Given this list of marker genes Ywhab, Mtm1, Phlpp1, Ppp1cb, Ptpn5, Tmem225, Dusp16, Ptpro, Ppp1r35, Rpap2, Cd33, Dusp21, Ptprn, Slc39a10, Ppa2, Ptpn3, Ppp1r15a, Hsp90ab1, Ppp2r2a, Ppp2r5c, Dusp12, Cdc25a, Ppp1r3c, Bod1, Phactr1, Calm3, Ppm1b, Ppm1n, Ppp1r36, Ptprb, Ppp1r14a, Tns2, Ptprk, Ptprg, Styxl2, Ppp3r2, Dusp5, Ppp5c, Ppp3ca, Rngtt, Pald1, Rcan3, Ptpn23, Ptpn14, Cdc14b, Ppp1r11, Ptpn2, Ppm1a, Tns3, Ptprn2, Pdp2, Ptprs (NCBI Gene Id 19280), Fig4, Pgp, Ptprf, Cabin1, Ppp1r15b, Ppm1e, Ptpn20, Ptprt, Ptpn22, Ctdnep1, Ppp1r8, Dusp9, Ppp1r7, Ctdspl, Phlpp2, Ppp6r1, Dusp10, Ppp2r5d, Dusp7, Ppp4r3c1, Smtnl1, Ptprq, Ppp2r5e, Ppp2cb, Ppp1r10, Eya2, Ppp2r1b, Dusp11, Ppp1r2, Cnep1r1, Dusp19, Elfn2, Pabir2, Ppp1r1b, Eya4, Ppp1r1a (protein phosphatase 1, regulatory inhibitor subunit 1A), Ptpra, Ppp1r17, Dusp15 (NCBI Gene Id 99102), Ppp1r14b, Dusp29, Htt, Dusp28, Ptpn1, Ptpru, Cdkn3, Eya3, Ptpn6, Mtmr4, Ppp2r3a, Ensa, Ppef1, Ppp1r16a, Ppm1j, Ppp4r3a, Cdca2, B3gat3, Ptpn7, Ambra1, Ppp1r3e, Calm1, Ppp3cc, Elfn1, Ppp1r14c, Pptc7, Dmpk, Ppp4r4, Tprn, 2810408A11Rik, Ctdsp2 (CTD small phosphatase 2), Ppp2r5b, Ppp1r14bl, Ppp1r3d, Dusp8, Ppp1r3a, Ppp2r2d, Ppp1r27, Dusp2, Tiprl, Mdp1, Ywhae, Acp3, Ptpdc1, Ppm1g, Vrk3, Ppp3cb, Lmtk2, Ptp4a1, Ppm1d, Ppp4r3b, Pdxp, Ptpn18, Arpp19, Ppp2r3d, Ppm1h (protein phosphatase 1H (PP2C domain containing)), Ptprj, Ppp2r2c, Ctdspl2, Ptn, Nit1, Ppp2r2b, Ptprd, Ptprh, Ppp1r14d, Ppp2r5a, Ptpn11, Calm2, Pdp1 (NCBI Gene Id 381511), Mgat5, Ptprz1, Pabir1, Myoz1, Dusp4, Cpped1, Dusp3, Ptp4a3, Ptpn9, Hsp90b1, Dusp1, Ptk2, Ppp1cc, Ppp1r1c, Cry2, Dusp14, Ppp1ccb, Acp4, Pp2d1, Ppp4r1, Ptprr, Ssh1, Ctdp1 (NCBI Gene Id 67655), Ptprc, Ppp1r26, Ssu72, Ppp1r9b (NCBI Gene Id 217124), Ppp6r2, Mtmr3, Ptpn12, Igbp1, Ppp1ca, Igfbp2, Lck, Ppp4r3c2, Rcan2, Tns1, Ppp1r12b, Eya1, Ppp6r3, Dusp6, Dusp26, Acp2, Acp1, Wbp11, Ptp4a2, Pgam5, Dusp13a, Dnajc6, Ptpmt1, Sh3rf2, Gna12, Ptpa, Ppp1r37, Epm2a, Cdc14a, Uri1, Phpt1, Dusp23, Phactr4, Ppp4r2, Ppp1r12a, Ssh3, Cdc25b, Ptpn13, Ppp6c, Tab1, Ppp4c, Timm50, Ptpn21, Ssh2, Dusp18, Pten, Styxl1, Dusp13b, Ppp1r12c, Ppp1r16b, Ctdsp1, Csnk2a1, Igfbp3, Ptprm, Ptpre, Phactr3, Dusp22, Sirpa, Bckdk, Ptprv, Cip2a, Ptpn4, Ppp3r1, Ilkap, Ppm1m, Rcan1, Ppef2, Ppp1r3b, Ubash3b, Ublcp1, Cmya5, Ppp2ca, Ppp2r1a, Cdc25c, Ppm1f, Ppm1l, Ppm1k, here is a description of the gene set: Mouse Gene Set: GOMF_PHOSPHOPROTEIN_PHOSPHATASE_ACTIVITY species: Mus musculus Catalysis of the reaction: a phosphoprotein + H2O = a protein + phosphate. Together with protein kinases, these enzymes control the state of phosphorylation of cellular proteins and thereby provide an important mechanism for regulating cellular activity.